The following is a description of a gene set: The Wnt signaling pathway is deregulated in over 90% of human colorectal cancers. beta-Catenin, the central signal transducer of the Wnt pathway, can directly modulate gene expression by interacting with transcription factors of the TCF/LEF family. In the present study we investigate the role of Wnt signaling in the homeostasis of intestinal epithelium by using tissue-specific, inducible beta-catenin gene ablation in adult mice. Block of Wnt/beta-catenin signaling resulted in rapid loss of transient-amplifying cells and crypt structures. Importantly, intestinal stem cells were induced to terminally differentiate upon deletion of beta-catenin, resulting in a complete block of intestinal homeostasis and fatal loss of intestinal function. Transcriptional profiling of mutant crypt mRNA isolated by laser capture microdissection confirmed those observations and allowed us to identify genes potentially responsible for the functional preservation of intestinal stem cells. Our data demonstrate an essential requirement of Wnt/beta-catenin signaling for the maintenance of the intestinal epithelium in the adult organism. This challenges attempts to target aberrant Wnt signaling as a new therapeutic strategy to treat colorectal cancer. species: Homo sapiens from publication Fevr T, Robine S, Louvard D, Huelsken J (PMID 17785439) Genes up-regulated in intestinal crypt cells upon deletion of CTNNB1. Human Gene Set: FEVR_CTNNB1_TARGETS_UP, and this is the list of marker genes: AKR1B15, NR1H4 (nuclear receptor subfamily 1 group H member 4), SDCBP2 (syndecan binding protein 2), CRYBG2, IL13RA1, LGALS8, SLC6A8, GZMB, ELANE, PKD1, STX3, EGLN3, JUN, CYP51A1, ARIH1, STAT1, NATD1, CYP4A11, SCAMP1, NHERF1, S100A8, CTSO, FAM83E, ELOVL6, GPD2, FOS, ATOH1, AQP11, RHBDF1, KCNK5, TMEM120A, CDS2, RNF103, AP2A2, TNFAIP1, SERPINB1, LAMA3, EIF2AK3 (eukaryotic translation initiation factor 2 alpha kinase 3), POU2AF2, HEPACAM2, GBA1, SECISBP2L, CDC42EP2, CHST2, UBFD1, SSBP2, SLC1A1, LPAR3, IL15, CGREF1, MTTP, B3GALT5, EEF2K, SEC22C, FLOT1, C11orf24, RAB7A, HELZ2, SEC61A1, PDLIM2, TRADD, SGK2, CTSV, CACNA1D, P4HA1, OAS2, SLC7A7, CSRNP1, LTB4R, IL17RC, RRAS, MFAP1, NAIP, CD36, KLK6, PIGB, MKNK1, CIITA, SLC15A1, POR, CDS1, MLPH, MAOB, EVPL (NCBI Gene Id 2125), HLF, AMN, FAM221A, HOXA5, DLG3, TMEM164, MOB4, BMP5, SPHK1, RNF114, ATF5, LIPA, CAPN9, NEU1, CST6, RORA, EEPD1, SYNPO, DDAH1, PIM1, APOBEC1, KLK5, GSR, PROCR, ACOX1, PABIR1, CEBPB, IL10RB, TRIM25, BLOC1S6, HAGH, ACE2, SGPL1, PLEK, SLC3A1, GRK2, AOC1, AQP7, PCSK5, SLC2A1, PARD6B, TAP2, KLF3, MIEN1, ERMP1, FAM78A, RELB, ERO1A, IFIT3, DUSP1, CCL5, PDE6D, CYP2U1, CORO2A, G0S2, GPR27, GSDMC, GUK1, BTG2, NDUFS5, SPP1, PLA2G1B, UGP2 (UDP-glucose pyrophosphorylase 2), TRIM34, ME1, SGMS2, UNC5B, GK, SERP1, HLA-DQB2, C6orf89, PRRG2, ZNF652, STK17B, NPDC1, PIP5K1B, XDH, ACAP1, HLA-DMB, SERPINI2, GTPBP2, STAT3, SLC5A8, COX7A1, GDAP2, AGPAT3, MAP4K5, LDB3, ATF3, RAB2A, SDCCAG8, SPINK1, ITPRID2, PDE2A, CASP9, VAT1, MPZL3, INSIG2, KCTD5, MCUR1, MST1R, CMPK2 (cytidine/uridine monophosphate kinase 2), NAB2, PNLIPRP1, KDELR3, GNAI1, TRIOBP, CDKN1A, DDX60, GPR35, ACYP2, BNIP2, LPIN2, TMC5, EPHA1, GIP, MAP4, PPY, ZBP1, JKAMP (NCBI Gene Id 95097), OPLAH, TRPM5, SLC52A3, KLK9, REG3A, ABCA3, PNPLA6, OPTN, AMY2A, DBP, UPP1, BCL6, TGFBI, SPATS2L, SOWAHB, CABP2, BORCS6, BCR, ZNF467, CD8A, PDE9A, PYCR1, IGSF23, RPL17, CDKL2, MARK2, IAPP, ABHD2 (NCBI Gene Id 654057), S100A6, SLC38A3, ADM, PAH, TRIM16, PCYT2 (NCBI Gene Id 5833), DOCK5, GPT, ATP8A1, SLC22A3, MVP, TRIM26, HCK (HCK proto-oncogene, Src family tyrosine kinase), TTC39A, LIPH (lipase H), LGALS1, GATA5, GSN, VPS52, GP2, WBP2, FKBP11, CLCA1, LETM1, SMG1 (NCBI Gene Id 23049), VAPB, MAFF, FXYD1, LMNA, PTPRE, PDGFRB, OAS1, CXCL6, SLC31A1, PPP1R16A, MCFD2, REG3G, ITIH4, CRAT, CLSTN1 (calsyntenin 1), CXCL16, SRC, PSTPIP2, SLC26A3, FAM83G, SUCO, TSC22D3 (NCBI Gene Id 64477), FMO5, COTL1, GNPDA1, CDK18, RAB21, RAB6A, APOA1, PMP22, MAPK6 (mitogen-activated protein kinase 6), MTPN, GCNT1, PRKAR1A, PER1, CPA1, JUNB, UGCG, CCKAR (NCBI Gene Id 886), CYP2D6, GCG, ABHD18, RAB3D, PFKFB2, HLA-DMA, GP1BB, SEMA7A, GALE, HMGCS1, SLC49A4, ITGB5, HYAL2, GATM, LGALS3, BACE2, TM6SF2, TNFSF13B, TRIO, APOL3, PTPRR, CTTN, BORCS7, HSD17B2, MMP15, CLDN3, EPS8L2, AP5M1, ITPKA, PRXL2A, GOT1, EPB41L3, ABLIM1, CLN8, GCLC, PLEKHG1, ARFGAP3, COPZ2, CELA1, B3GALT4, FDFT1, CTRL, SLC47A1, CLCN2, SLC35C2, SOCS3, WNT5A, NCBP3, IP6K1, SFN, VTN, ATP2C2 (NCBI Gene Id 9914), MS4A8, SPTA1, MYO7A, TRPM7, CPE (carboxypeptidase E), C2, ATOSA, GFI1, SPRR2G, ATP11B, LYST, C3, ZYX, STAT2, CAPN15, CLIC5, IGSF9 (immunoglobulin superfamily member 9), NUCB2, SOAT2, MACIR, HGFAC, EMC9, OCLN, TNFRSF21, MAPK8, ITGA3, OSBPL6, STK10, CILK1, MTM1, TFIP11, KRT20 (NCBI Gene Id 54474), EPS8, PROC, SLC22A23, CSF1R, APOC3, LTC4S, OTUD7B, HIF1A, MT2A, SLC3A2, DHX58, TTC39B, FAM210B, ACACB, ANK3, IFI27L1, ENTPD5, CAPNS1, SAMHD1, WFS1, APBA3, IRF7, JAK2, MTF1, DUSP6, SLC46A3, AP3M2, CORO1C, RAB37, PYY, CYP4F2, STK38L, IRAK4, VAMP5, CYTH2, CPB1, SPARC, CHD2, STX7, SERPINH1, GNG12, OGA, TRIM8, KHNYN, STXBP1, CDC42BPB, CDR2, PHYKPL, OASL, GGA1, SRR, EMP1, KIF3B, ANGPTL4, PCSK7, ERP27, ODR4, CAMTA2, GGT1, SLC6A3, FOSL2, SERHL2, DGKA, MFSD9, FAM114A1, CKB, HP, KLF7, AGPAT4, SLC11A2, KIFC2, DSG2 (desmoglein 2), FN1, DNAJB2, FABP1, FBXW2, SERPINB5, GPD1, ABCB1, DHX34, TEPSIN, MIDN, SLC27A4, VPS41, USP18, ATP2A3, GABBR1, SLC51B, ABCA7, GADD45B, GNMT, LY6E, SUSD6, HLA-DQA1 (major histocompatibility complex, class II, DQ alpha 1), TCF23, SYT12, ATP6V0A2, NRP2, GPR107, SYNE2, GADD45G, IFI27L2, CLU, PCSK9, CTSB, DGAT2, SNRNP70, B3GNT3, SLC20A1, HNF1B, RNF181, ABCB10, REEP3, HAL, SLC6A6, TNFAIP3, SLCO2A1, PDE7A, RAB20, RHBG, ANXA2, H1-2, MCL1, SLC35E2A, PRKCZ, RRBP1, PARM1, CEL, HSPA1B, ACTA1, LPIN1, SCT, ARHGDIG, UBL5, CDC42EP5, IER5, REG1B, SMOX, EFNA1, NOL4L, CDKN2B, MCUB, BST1, NEK3, IL33, TTLL8, SFTPC, TMEM150A, AP3M1, FAAH, RFNG, SOSTDC1, PRSS3 (serine protease 3), H6PD, TMEM214, GNA13, HSD17B7, DPEP1, SAA2, TGOLN2, CA4, MMP2, CORO1A, BHLHE40, BBLN, RNF19A, DDX39B, GPX2, TMC7, GLO1, MVD, ABR, DUSP8, PMM1, LITAF, RAB4A, COL1A2, OGDH, GINM1, FAM53B, SLC12A7, GADD45A, SULT2B1, MFSD6L, ERP44, CAP1, GHDC, EDN3, LRRC26, TAP1, INS, MATK, PGD, EIF2AK1, NDFIP1, AGR2, ATOSB, PRKCA, NDEL1, RBPJL, CA3, CBR3, PLXNB2, H2AC18, CYTH1, BCO2, SYCN, GOSR1, MEP1B, TOLLIP, CLMN, SEC14L2, ADK, SLC2A8, FLVCR2 (FLVCR choline and putative heme transporter 2), DAP, FAM3D, GUCA2B (NCBI Gene Id 2981), PIK3C2A, PLA2G6, HSD17B6, ACER3, TNFRSF12A, MUC1, CYP27A1, PTGER3, CRY2, TMEM140, KRT12 (keratin 12), ABCG5, CASP4, URGCP, BNIP5, SURF4, H3C13, GABARAPL1, FABP6, GNA11, SYT7, CA13, CPEB3, IFIT1B, PREB, DAGLB, MMP10, CBS, MIA2, ACKR4, GSTA5, RNASE1, MYO18A, FAM3B, PRDX2, RETREG1 (NCBI Gene Id 96119), ACE, ABCD1, EFNB2, SLC28A3, CASP3, SYTL2, APLNR, SPATA2, TFF2, ASPA, DDIT3, CD163, CLPS, ADPRM, CXADR, ATP5F1A, ELMO2, IRF1, CEBPA, DPP4, DHRS1, SEC14L1, SOCS7, PNLIPRP2, SLC12A8, BLOC1S5, ALDH1A1, OSGIN1, HLA-E, ZSCAN21 (NCBI Gene Id 85010), SLC2A9, IL1RL1, CREB3, MB21D2, MT1A, PTK6, CIDEB, CGN, TYMP, PLCG2, P2RX4, CCN2, REP15, MS4A10, EPS8L3, LAMB3, PKLR, HPGD, CHP2, F11R, GSTK1, SLC7A9, GPC4, LSS